The following is a description of a gene set: species: Homo sapiens A homeostatic process involved in the maintenance of a steady state level of zinc ions within a cell. Human Gene Set: GOBP_INTRACELLULAR_ZINC_ION_HOMEOSTASIS, and this is the list of marker genes: MT1X, SLC39A6, MT1H, MT1M, SLC30A7, MT4, MT1E, MT1A, TMC6, SLC30A8, SLC39A14, MT1HL1, MT1G, AP3B1, ATP7B, SLC39A13, MT1F, SLC30A1, LCK, MT2A (NCBI Gene Id 4502), SLC1A1, TMC8, SLC39A9, ATP13A2, SLC39A8, MT3, SLC30A10, SLC30A2, SLC30A5, SLC39A4, MT1DP, SLC39A7, SLC39A10, MT1B, SLC30A9